The following is a description of a gene set: Human Gene Set: CHEN_ETV5_TARGETS_TESTIS Genes down-regulated in testis from 4 week old ETV5 knockout mice. Division of spermatogonial stem cells produces daughter cells that either maintain their stem cell identity or undergo differentiation to form mature sperm. The Sertoli cell, the only somatic cell within seminiferous tubules, provides the stem cell niche through physical support and expression of surface proteins and soluble factors. Here we show that the Ets related molecule (ERM) is expressed exclusively within Sertoli cells in the testis and is required for spermatogonial stem cell self-renewal. Mice with targeted disruption of ERM have a loss of maintenance of spermatogonial stem cell self-renewal without a block in normal spermatogenic differentiation and thus have progressive germ-cell depletion and a Sertoli-cell-only syndrome. Microarray analysis of primary Sertoli cells from ERM-deficient mice showed alterations in secreted factors known to regulate the haematopoietic stem cell niche. These results identify a new function for the Ets family transcription factors in spermatogenesis and provide an example of transcriptional control of a vertebrate stem cell niche. species: Mus musculus from publication Chen C, Ouyang W, Grigura V, Zhou Q, Carnes K, Lim H, Zhao GQ, Arber S, Kurpios N, Murphy TL, Cheng AM, Hassell JA, Chandrashekar V, Hofmann MC, Hess RA, Murphy KM (PMID 16107850), and this is the list of marker genes: SOX3, DDX10, RAD51 (NCBI Gene Id 5888), CDK2, CCNE2, MKI67, CCNB1IP1, AK4, DMC1, RNF227, HAUS6, RBL1, STRA8, FAM9A, CRABP1, DAZL, RBMY1B, MAD2L1, TGFBR1, MCM2, TKTL1, HELLS, DCK, CDCA7, NFYB, PACRGL